Given this list of marker genes INTS13, AQP3, DDX11, IFFO2, NLRP1, SNX14, ZNF836, ZNF431, KIF2A, SLC39A10, CD58, ATP2A3, NIPAL3 (NIPA like domain containing 3), CDC7, ACSL5, DDB2, CD274, RNF157, CCM2, CCR5, SIT1, INO80E, IFIH1, ACSS1, MAEA, ORC4, PCYT1A (phosphate cytidylyltransferase 1A, choline), KLHDC4, TGIF2, RPL8, CENPN, HELB, SLAMF1, PARP11, ZNHIT6, FCRL6, CSF2, DIAPH1, TMEM273, SAP30, GIMAP6, ARID3B, BMAL1, PTGDR, ABTB1, GPR18, GSKIP, ZNF721, ZFAND2B, TENT4B, GLMN, USP12, LAIR1 (NCBI Gene Id 3903), RGS19, TMEM154 (NCBI Gene Id 201799), COX18, KDM2A, BRD1, DBP, APOBEC3D, RAPGEF6, SNX10, KAT7, ERAP2, TOMM5, SPN, TRIM59, TRIM26, TEPSIN, SYTL2, FASLG, GPR155, BCL7B, RPL37A, MTFP1, SNAI3 (snail family transcriptional repressor 3), IL27RA, PTPN6, PILRB, TUT7, CDK5R1, ZNF276, SYNRG, PATJ, AP4B1 (NCBI Gene Id 10717), PAPOLG, ZBTB37, FAM136A, MTERF4, C6orf120, RINL, CRNKL1, ZC3H18, H2BC18, MXD4, TNFSF4, RANBP3, CNST (consortin, connexin sorting protein), SPATA2L, CUTALP, THEMIS, MIR155HG, FERMT3, NKAP, INPP4A, NUBP2 (NUBP iron-sulfur cluster assembly factor 2, cytosolic), PDCD2, MFSD14CP, ZNF266, MT-CO1 (NCBI Gene Id 4512), CERK, ITFG2 (integrin alpha FG-GAP repeat containing 2), ASF1A, MAN2B1, CDIP1, N4BP2, CAMK2G, CHD7, MIAT, here is a description of the gene set: Human Gene Set: GAUTAM_EYE_CHOROID_SCLERA_ACTIVATED_T_CELLS from publication Gautam P, Hamashima K, Chen Y, Zeng Y, Makovoz B, Parikh BH, Lee HY, Lau KA, Su X, Wong RCB, Chan WK, Li H, Blenkinsop TA, Loh YH (PMID 34584087) studied in species Homo sapiens Occular cell types curated from Gautam and Hamashima et al. Multi-species single-cell transcriptomic analysis of ocular compartment regulons